The following is a description of a gene set: Regulation of SERCA. Pathway ID: N01646. Pathway type: Reference. Pathway class: nt06528 Calcium signaling. studied in species Homo sapiens Pathway Definition from KEGG: (PLN,SLN,MLN,ELN,ALN) -| ATP2A Human Gene Set: KEGG_MEDICUS_REFERENCE_REGULATION_OF_SERCA, and this is the list of marker genes: PLN, C4orf3, ATP2A1, MLN, ATP2A2, ATP2A3, ELN, SLN